Given this list of marker genes WIPF1, BBS4, BBS2, SETD2, TRIP13, LZTFL1, SLFN14, EIF2B3, SOS1, DIAPH2, WWOX, CTDP1 (NCBI Gene Id 9150), CDON, BMPR1B, PHKB, MKKS, USP48 (NCBI Gene Id 84845), SMC1A, LZTR1, PSMD12, ZFPM2 (NCBI Gene Id 56958), ARL6, IFT74, PAPSS2, MRPS22, APOLD1, PDE4D, GDF9, F5, DCC, DNM1L, SIM1, MSH4, FYB1, F13B, PWAR1, GNRHR, FGG, AGPAT2 (1-acylglycerol-3-phosphate O-acyltransferase 2), NPHP1 (NCBI Gene Id 4867), POLG, AXL, TPM4, WNT7A, EIF2B1, SPRED2, WNT4, SLC25A13, SOX10, NR3C1, PLAU, SOST, PDGFB, ITGA8, CEP290, NDNF (NCBI Gene Id 79625), MCFD2, SERPINE1, CYB5A, DUSP6, MEN1, GP1BB, F13A1, TRIM32, NHLH2, CYP17A1, FANCM, SNORD115-1, GP1BA, OCA2, SUFU, USP8, MEIOB, EIF2B2, TBL1X, HARS2 (histidyl-tRNA synthetase 2, mitochondrial), CEP19, ERAL1, BNC1, BBS12, BBS10, AKT2, AIP, RARA, NOBOX, TTC8, SNORD116-1, MPV17, PROK2, STAT3, PEX10, ZBTB16, PIK3CA, NPM1, SLC37A4, HESX1, LIPE, ATRX, SMARCB1, PPARG, GLI2, NUMA1, HROB, TACR3, H6PD, PRLR, BBS7, BPTF, PSMB8, RRAS2, NABP1, PHKA2 (NCBI Gene Id 5256), MCM9, ZSWIM7, SOS2, TP53, F7, VAMP7, F8, C14orf39, EIF2B4, LEP, GATA3, WAS, NIPBL, CAV1, GNRH1, PCSK1, SYCE1, SOX3, KRAS, FOXA2, SRY, POR, RAD21, CDH23, GATA4, SCLT1, CDKN2C, CIDEC, RRAS, DTNBP1, SNRPN, FBXO11, DIAPH1, NR5A1, ROBO1, TAF6, FSHR, CYP19A1, MKRN3, PRORP, CFAP418, BBS1, WRN, MSH5, NPAP1, FMR1, BCOR, GPR101, FSHB, TBL1XR1, ERCC8, BMP15, PROKR2, STAT5B, SMCHD1, SMO, PEX1, SYCP2L, HPS4 (NCBI Gene Id 89781), HERC2, SEMA3A, KPNA7, FGFR1, HMGA2, KISS1R, ERCC6, CBL (NCBI Gene Id 867), TRAF7, FIGLA, FOS, GNAS, IGF2, SPATA22, LIG4, BSCL2, NF2 (NF2, moesin-ezrin-radixin like (MERLIN) tumor suppressor), BBIP1, MSTO1, PTPRJ, ANTXR1 (NCBI Gene Id 84168), RCBTB1, PNPLA6, FOXL2, RAF1, CDKN1A, HPS5, PLAG1, IFT27, BBS9, FLRT3, SOHLH1, HSD17B4, NUP107 (NCBI Gene Id 57122), MYH9, GP9, LMAN1, CCDC141, HFM1, MOS, KASH5, PWRN1, SMC3, CHD7, F11, TAC3, PTPN11, WT1, YARS1 (NCBI Gene Id 8565), GP6, STAG3, HFE, BTG4, LHB, SPIDR, SLC29A3, FLI1, SMARCE1, HS6ST1, FGFR3, PLIN1, BLOC1S3, KISS1 (NCBI Gene Id 3814), PHKG2, IRF2BP2, NBEAL2, GHR, CYP11B1, MCM8, POLG2, PEX6, IL17RD, NSMF, DHX37 (NCBI Gene Id 84742), ANOS1, BMP2, FIP1L1, CDKN1B, ESR1, OTX2, POLR3H, TRMT10A, BBS5, IFT172, AKT1, MKS1, NRAS, NR0B1, LEPR, AGGF1, RIT1, SCAPER, ZMPSTE24, VWF, CAVIN1, CISD2, FEZF1, KDM1A, ITGB3, PSMC3IP (NCBI Gene Id 51769), WDR11, ITGA2B, RNF216, TKT, PRKACG, BAP1, TWNK, RASGRP2, MAGEL2, SPRY4, BMP6, HAMP, FGF17, FGB, SDCCAG8, AR, SOX9, ARMC5, MRAS, PROP1, HSF2BP, ATP7B, ESR2, MAP3K1, CDKN1C, TFR2, LHX4, PML, NDN, POF1B, F10, LMNA (lamin A/C), TP63, RASA2 (NCBI Gene Id 5922), SEMA3E, PRKAR1A, CCDC28B, STUB1, CLPP, GNE (glucosamine (UDP-N-acetyl)-2-epimerase/N-acetylmannosamine kinase), WDPCP, LARS2, NIN, F2, CPE, SRA1, BLOC1S5 (NCBI Gene Id 63915), BRAF, TPR, FGA, HDAC8, POU1F1, ALMS1, DHH, CDKN2B, BRD4, GALT, GPR161, TERT, HJV, FGF8, here is a description of the gene set: Human Gene Set: HP_ABNORMALITY_OF_THE_MENSTRUAL_CYCLE Abnormality of the menstrual cycle An abnormality of the ovulation cycle. studied in species Homo sapiens